The following is a description of a gene set: Depolymerization of the Nuclear Lamina studied in species Homo sapiens Human Gene Set: REACTOME_DEPOLYMERIZATION_OF_THE_NUCLEAR_LAMINA, and this is the list of marker genes: LEMD3 (NCBI Gene Id 23592), CDK1, CTDNEP1, PRKCA, EMD, LPIN2, PRKCB, LPIN1 (lipin 1), TMPO, LPIN3, CNEP1R1, LEMD2, LMNB1, CCNB1, LMNA